The following is a description of a gene set: species: Mus musculus The action of a molecule that contributes to the structural integrity of a synapse. Mouse Gene Set: GOMF_STRUCTURAL_CONSTITUENT_OF_SYNAPSE, and this is the list of marker genes: Mpp2, Dlg2, Ctnnd2, Nefh, Dlg3, Rimbp2, Sptbn2, Camk2b, Dlg1, Dlgap1, Shank1, Rims2, Homer1, Dbnl, Erc1, Shank3, Dnm3, Rims3 (NCBI Gene Id 279225, regulating synaptic membrane exocytosis 3), Bsn, Rims1, Actn1, Acte1, Rapsn, Ppfia2, Dlg4, Actn2, Ctbp2, Actbl2, Git1, Ina, Actb, Actg1, Nefl, Pls3, Pclo, Erc2, Shank2, Magi2, Septin7